Given this list of marker genes MLX, AGPAT1, MLXIPL, ACACB (acetyl-CoA carboxylase beta), PKLR, ACACA, ACLY, FASN, here is a description of the gene set: Reactome Pathway: ChREBP activates metabolic gene expression species: Homo sapiens part of: Integration of energy metabolism ChREBP (Carbohydrate Response Element Binding Protein) is a large multidomain protein containing a nuclear localization signal near its amino terminus, polyproline domains, a basic helix-loop-helix-leucine zipper domain, and a leucine-zipper-like domain. Its dephosphorylation in response to molecular signals associated with the well-fed state allows it to enter the nucleus, interact with MLX protein, and bind to ChRE DNA sequence motifs near Acetyl-CoA carboxylase, Fatty acid synthase, and Pyruvate kinase (L isoform) genes (Ishi et al.2004). This sequence of events is outlined schematically in the picture below (adapted from Kawaguchi et al. (2001) - copyright (2001) National Academy of Sciences, U.S.A.).